Given this list of marker genes Dkk4, Bmp2, Neo1, Dkk3 (NCBI Gene Id 97412), Tfr2, Bmp4, Wnt3a, Dkkl1 (dickkopf-like 1), Wnt9b, Dkk2, Hfe, Dkk1, here is a description of the gene set: Mouse Gene Set: GOMF_CO_RECEPTOR_BINDING Binding to a coreceptor. A coreceptor acts in cooperation with a primary receptor to transmit a signal within the cell. studied in species Mus musculus